Given this list of marker genes OAS2, RAD54B, SAMSN1, DHRS9 (NCBI Gene Id 10170), SLC20A1, RABGEF1, HIGD1A, CTH, SLC7A11, FOS, PDLIM4, EPRS1, MTHFD2, DUSP4, APBA3, KLF4, SKIL, CSF3, PNRC1, IFRD1 (interferon related developmental regulator 1), MMP8, RIOK1, TRPS1, VANGL2, SLC39A14 (solute carrier family 39 member 14), CEBPB, ANKRD1, FST, RAMP3, ATF4, CXCL2, ITGA6, TSHZ1, CARS1, ZNF330 (NCBI Gene Id 94900), GSPT2, PPP1R15A, GZF1, ADM, XBP1, SMOX, ANPEP, GADD45A, THBD, HBEGF, VLDLR (very low density lipoprotein receptor), CXCL10, SAT1, ALDH1L2, DUSP2, SRGN, USP47, HAX1, GBE1, CD44, IRGM, FGD6, CACNA1H, AKAP12, RCAN1, KCTD11, HILPDA, CHIC2, KLF6, PYHIN1, NOCT, SLPI, ZNF398, GFUS, HSPA5, ERO1A, NDRG1, MAP3K1, LAMP2, VEGFA, RAD23B, SIAH2, MYH9, ACAP2, RND1, CD93, ZFP36 (NCBI Gene Id 7538), ASCC2, ZBTB20, PLK2, CCN2, JAG1, ATF1, EGR1, GJA1, MYC (MYC proto-oncogene, bHLH transcription factor), FBXO42, ACBD3, FGB, TGIF1, NEDD4L, NFKBIA, RBPJ, CDC42EP3, VWA1, ASNS, EPS15, TNC, AFF1, LHX9, CXCL6, PRDM2, ANGPTL6, CAVIN3 (NCBI Gene Id 8990), NEDD9, ADIPOR2, SLC2A1, TCIM (NCBI Gene Id 56892), S100A8, SCAF11, C3, CCN1, PTGER4, DZIP3, TIAM2, DMP1, UPP1, ACSL4, BHLHE40, PFKFB3, HOXB9, TRAF6 (TNF receptor associated factor 6), PTBP3, CCL2 (C-C motif chemokine ligand 2), TXNL1, EDN1, ENO1, ERRFI1, RPS6KA5, PLEK, ATXN2L, RARS1, ETS1, PRKG2, PRDX5, DEPP1, SPRY2, IL13RA1, CSRNP1, PTGS2, BCL10, NFIL3, PDLIM5 (PDZ and LIM domain 5), KIF5A, IL6, JMJD1C, TM4SF1, EHF, PIM3, here is a description of the gene set: The ternary complex factor Net/Elk3 is downregulated in hypoxia and participates in the induction by hypoxia of several genes, including c-fos, vascular endothelial growth factor and egr-1. However, the global role of Net in hypoxia remains to be elucidated. We have identified, in a large-scale analysis of RNA expression using microarrays, more than genes that are regulated by Net in hypoxia. In order to gain insights into the role of Net in hypoxia, we have analysed in parallel the genes regulated by HIF-1alpha, the classical factor involved in the response to hypoxia. We identified about genes that are regulated by HIF-1alpha in hypoxia. Surprisingly, when we compare the genes induced by hypoxia that require either Net or HIF-1alpha, the majority are the same (75%), suggesting that the functions of both factors are closely linked. Interestingly, in hypoxia, Net regulates the expression of several genes known to control HIF-1alpha stability, including PHD2, PHD3 and Siah2, suggesting that Net regulates the stability of HIF-1alpha. We found that inhibition of Net by RNAi leads to decreased HIF-1alpha expression at the protein level in hypoxia. These results indicate that Net participates in the transcriptional response to hypoxia by regulation of HIF-1alpha protein stability. species: Mus musculus Human Gene Set: GROSS_HYPOXIA_VIA_ELK3_DN from publication Gross C, Dubois-Pot H, Wasylyk B (PMID 17704799) Genes down-regulated in SEND cells (skin endothelium) at hypoxia with ELK3 knockdown by RNAi.